Given this list of marker genes Vegfb, Flt1, Vegfd, Pgf, Kdr, Flt4, Vegfc, Vegfa, here is a description of the gene set: Mouse Gene Set: REACTOME_VEGF_LIGAND_RECEPTOR_INTERACTIONS studied in species Mus musculus VEGF ligand-receptor interactions